The following is a description of a gene set: Human Gene Set: HP_ABNORMAL_POSTERIOR_SEGMENT_IMAGING studied in species Homo sapiens Abnormal posterior segment imaging, and this is the list of marker genes: REEP6, NRL, CERKL, ARL3, RP9, PMM2, KLHL7, KIAA1549, PDE6C, GUCA1A (guanylate cyclase activator 1A), CLRN1, CNGA3, IFT88, AHR, KIZ, PRPH2, SPATA7, EFEMP1 (EGF containing fibulin extracellular matrix protein 1), DHDDS, CFH, EYS, PAX6, CLEC3B, TTC8, RP2, SNRNP200, TOPORS, RP1, GUCY2D, RPGR, RLBP1, IDH3B, TLCD3B, SELENOI, BBS1, TUB, SLC7A14, IMPG2, KIF3B, POMGNT1, OPN1LW, SAG, MFSD8, RGR, MERTK, CWC27, TTLL5, RAX2, ARHGEF18, DHX38, ABCA4 (ATP binding cassette subfamily A member 4), BEST1, CRB1, HGSNAT, AHI1, MAK, AGBL5, NEK2, IFT140, TRNT1, PCARE, FSCN2, FOXC1, CC2D2A (NCBI Gene Id 57545), LRAT, PDE6B, OPN1MW, TULP1, CFI, BBS2, CCDC28B, SEMA4A, ZNF513, FAM161A, CA4, OFD1, CNGA1, PRPF4, PRPF31, PRCD, CFAP418, ZNF408, AIRE, NR2E3, CLCC1, ATF6, GNAT2, RDH12 (retinol dehydrogenase 12), SLC6A6, TRIM44, ROM1, PRPF8, CNGB3, PRPF3, ARSG (arylsulfatase G), SLC24A5, SAMD7, ARL6, RBP3, IMPG1, ARL2BP, PDE6H, USH2A, PDE6G, RP1L1, HLA-A, PDE6A, PROM1, IFT172, CHM, SCAPER, RHO (NCBI Gene Id 6010), RS1, CRX, IMPDH1, CDHR1, CNGB1, IDH3A, TIMP3, PRPF6, GUCA1B, RPE65